The following is a description of a gene set: species: Mus musculus Any process that stops, prevents, or reduces the frequency, rate or extent of the cascade of processes induced by the cell cycle regulator phosphoprotein p53, or an equivalent protein, in response to the detection of DNA damage. Mouse Gene Set: GOBP_NEGATIVE_REGULATION_OF_DNA_DAMAGE_RESPONSE_SIGNAL_TRANSDUCTION_BY_P53_CLASS_MEDIATOR, and this is the list of marker genes: Kdm1a, Cd44, Dyrk1a, Snai1, Marchf7, Mdm2, Cd74 (NCBI Gene Id 16149), Pttg1ip, Mif, Sirt1, Dyrk3, Pcbp4, Twist1, Yju2, Snai2, Psmd10